Given this list of marker genes PIAS3, CREBBP, SIN3A, NCOR2, SUMO2, DDX5, ING2, PIAS1 (NCBI Gene Id 8695), SAFB, CBX8, UHRF2, NCOA1, HIPK2, TRIM28, PHC3, CBX2, ZNF131, NRIP1, RNF2, CASP8AP2, PHC2, CTBP1, DDX17, SUMO3, PHC1, CBX4, SCMH1, UBE2I, PIAS4, NCOA2, SUMO1, ZNF350, PPARGC1A, PIAS2 (protein inhibitor of activated STAT 2), PCGF2, NPM1, EP300 (NCBI Gene Id 2033), MRTFA, DAXX, MBD1, TOPORS, PARK7, BMI1, RING1, here is a description of the gene set: part of: SUMO E3 ligases SUMOylate target proteins Reactome Pathway: SUMOylation of transcription cofactors studied in species Homo sapiens SUMO1,2, and 3 are predominantly located in the nucleus and targets of SUMOylation are predominantly nuclear. Transcription cofactors are nuclear proteins that generally do not bind DNA themselves but interact with DNA-bound factors and influence transcription. SUMOylation of transcription cofactors usually inhibits the activity of the cofactor. In the cases of coactivators such as PPARGC1A (PGC-1alpha) this results in decreased transcription; in the cases of corepressors such as MBD1 this results in increased transcription.